The following is a description of a gene set: Reactions triggered in response to the presence of a virus that act to protect the cell or organism. Mouse Gene Set: GOBP_DEFENSE_RESPONSE_TO_VIRUS studied in species Mus musculus, and this is the list of marker genes: Irf3, Rpsa, Ifi44l, Cgas, H2-Q7, Cd207, Znfx1, Ifnb1, Ifngr1, Polr3h, Exosc5, Vapb, Zmpste24, Rnasel, Traf3ip3, Nlrc5, Ifnar1, Ifna2, Morc3, Pde12, Trim15, Serinc5, Chmp3, Trim13, Ddx17, Ddit4, Smarca5, Chuk, Unc13d, Hsp90aa1, Bnip3l-ps, Ddx1, Smurf1, Ifi208, C1qbp, Trim21, Gbp7, Map3k14, Ndufaf4, Bst2, Ifi207, Ifne, Apobec1, Ptprc, Irf2, G3bp1, Ifi27l2b, Ifnar2, Rb1cc1, Unc93b1, Traf3ip2, Il23r, Zbp1, Dus2, Ddx21, Ercc6, Usp18 (NCBI Gene Id 68782), Tarbp2, Trim52, Ifna12, Gbp2, Pla2g10, Dhx58, Abcf3, Trim11, Trim8, Mmp12, Akap1, Isg15, Slfn9, Tlr7, Trim41, Riok3, Tlr8, Htra1, Selenok, Bnip3l, Senp7, Ncr1, Mavs, Tbk1, Mx2, Trim28, Bcl2l1, Ifna7, Ifit1, Il10rb, Cd8a, Flicr, Ticam1, Il12b (interleukin 12b), Agbl4, Acod1, Nmb, Trim30b, Mlkl (mixed lineage kinase domain-like), Rnase6, Ifnk, Plscr1, Atg16l1, Gbp4, Il6, Oas1c, Nlrp6, Polr3b, Vamp8 (vesicle-associated membrane protein 8), Trim65, Polr3f, Elmod2, Ddx56, Samhd1, Ifi213, Ifih1, Becn1, Ube2w, Nlrp1a, Abcc9, Nck1, Sertad3, Nlrp9b, Trex1, Pmaip1, Apobec3, Zc3hav1, Rela (NCBI Gene Id 19697), Cxadr, Ifi203 (interferon activated gene 203), Ddx60, Trim34a, Stat2, Rnf185, Lyst, Il23a (NCBI Gene Id 83430), Irgm2, Trim44, Dhx16, Tagap, Gbp2b, Tspan32, Uap1, Usp20, Pcbp2, Ifi214 (interferon activated gene 214), Usp44, Dhx36, Phb2, Ilrun, Irf1, Ilf3, Ifit1bl1, Atad3a, Phb1, Gpr146, Tlr3, Ifi206, Sin3a, Ifitm1, Polr3k (NCBI Gene Id 98877), Oas1d, Rigi (RNA sensor RIG-I), Dicer1, Serinc3, Trim25 (NCBI Gene Id 22660), Trim34b (tripartite motif-containing 34B), Rnf26, Ncbp1, Gm12250, Treml4, Bcl2, Oas2, Stat1, Ifna11, Rtp4, Mill1, Usp27x, Gpr108, Itch, Trim6, Foxp3, Usp29, Polr3g (NCBI Gene Id 67486), Mbl2, Cnot7, Lsm14a, Atg5, Eif2ak4, Polr3e, Shfl, Atg14, Trim35, Tomm70a, Mul1, Ripk3, Prf1, Ifna1, Trim12a, Ifnl2, Hyal2, Il1b, Ppm1b, Ifit1bl2, Mid2, Ifna13, Oas3, Trim55, Ttc4, F2rl1, Ifi209, Gbp5, Nt5c3, Ptpn22, Zdhhc1, Ifnlr1 (interferon lambda receptor 1), Ifitm2 (interferon induced transmembrane protein 2), Skp2, Rnf216 (NCBI Gene Id 97262), Trim32, Igtp, Oas1a, Zcchc3, Hcfc2, Usp17le, Zmynd11, Crcp, Parp9, Il12rb1, Irf7, Traf3, Oas1b, Nlrp1b, Ifnl3, Ifitm6, Nlrp3, Ifitm7 (interferon induced transmembrane protein 7), Zdhhc11, Ifit2, Oprk1 (opioid receptor, kappa 1), Trim30d, Cxcl9, Marchf2 (NCBI Gene Id 78665), Aim2, Garin5a (golgi associated RAB2 interactor 5A), Atg7, Mndal, Ddx41, Rab2b, Oasl2, Oas1g, Polr3d, Sting1, Clpb, Nt5c2, Aicda, Ifi203-ps, Agbl5, Oas1h, Cd37, Trim26, Il33, Trim27, Eif2ak2, Creb3, Card9, Dhx9, Rsad2, Dtx3l, Oasl1, Ifna4, Irf5, Pqbp1, Spn, Ifna9, Trim12c, Ifngr2, Spon2, Rnf135, Ifna5, Ccl5, Ticam2, Trim7, Cxcl10, Il15, Ube2n, Adar, Mov10, Trim56, Fgl2, Polr3c (polymerase (RNA) III (DNA directed) polypeptide C), Trim31, Prkra, Traf3ip1, Traf6, Trim30c, Tnf, Trim30a, Ifna6, Rnf26rt, Armc5, Fadd, Atg12, Epg5, Il27, Cd86, Oas1e, Exosc4, Trim5, Itgax, Zc3h12a (zinc finger CCCH type containing 12A), Pml, Irgm1, Tlr9, Ifit3, Slfn8 (schlafen 8), Nmbr, Kcnj8, Fv1, Ncbp3, Tmem120a, Gpam, Casp1, Dhx15, Ifng, Pycard, Cd40, Ifit3b, Setd2, Ifitm3, Myd88, Isg20, Oas1f, Il4, Trim38, Bnip3